Given this list of marker genes Defb37, Ccr6, Tac2, Cfap69 (cilia and flagella associated protein 69), Prdm14, Iqcf1, Tacr2 (tachykinin receptor 2), Irgc, Tacr3, Spinkl, Or4m1, Adam7, Tacr1, Tac4, Ttll6, Defb1 (defensin beta 1), Rnase10, Tac1, Rnase9, here is a description of the gene set: Mouse Gene Set: GOBP_POSITIVE_REGULATION_OF_CILIUM_MOVEMENT studied in species Mus musculus Any process that increases the rate, frequency, or extent of cilium movement, the directed, self-propelled movement of a cilium.